The following is a description of a gene set: part of: Metabolism of proteins Reactome Pathway: Surfactant metabolism species: Homo sapiens The alveolar region of the lung creates an extensive epithelial surface that mediates the transfer of oxygen and carbon dioxide required for respiration after birth. Type I epithelial cells form the alveolar surface and mediate gaseous exchange. Type II epithelial cells secrete pulmonary surfactant, a lipoprotein complex that forms a thin interfacial film, lowering surface tension at the air-liquid interface in alveoli and maintaining the structural integrity of alveoli, preventing their collapse at low volumes (Agassandian & Mallampalli 2013). Surfactant production is increased prior to birth, in preparation for air breathing at birth. Pre-term infants, where type II epithelial cells are not fully differentiated yet, can produce insufficient surfactant and result in respiratory distress syndrome. Surfactant is composed primarily of phospholipids enriched in phosphatidylcholine (PC) and phosphatidylglycerol (PG) (Agassandian & Mallampalli 2013) and the pulmonary collectins, termed surfactant proteins A, B, C and D (SFTPA-D). They influence surfactant homeostasis, contributing to the physical structures of lipids in the alveoli and to the regulation of surfactant function and metabolism. They are directly secreted from alveolar type II cells into the airway to function as part of the surfactant. SFTPA and D are large, hydrophilic proteins while SFTPB and C are small, very hydrophobic proteins. In addition to their surfactant functions, SFTPA and D play important roles in innate host defense by binding and clearing invading microbes from the lung (Kingma & Whitsett 2006). Nuclear regulation, transport, metabolism, reutilisation and degradation of surfactant are described here. Mutations in genes involved in these processes can result in respiratory distress syndrome, lung proteinosis, interstitial lung diseases and chronic lung diseases (Perez-Gil & Weaver 2010, Whitsett et al. 2010, Akella & Deshpande 2013, Jo 2014)., and this is the list of marker genes: ZDHHC2, SFTPB, TTF1, SFTA3, SFTPC (NCBI Gene Id 6440), ABCA3, PGA4, P2RY2, GATA6, NAPSA, SLC34A1, CTSH, SFTPD (surfactant protein D), LMCD1, SLC34A2 (solute carrier family 34 member 2), CSF2RA, ADRA2C, CSF2RB, SFTPA1, PGA5, ADORA2B, ADRA2A, ADGRF5, CKAP4, ADORA2A, CCDC59, PGA3, SFTPA2, ADA2, DMBT1